The following is a description of a gene set: The directed movement of a protein to a specific location in a vacuole. studied in species Mus musculus Mouse Gene Set: GOBP_ESTABLISHMENT_OF_PROTEIN_LOCALIZATION_TO_VACUOLE, and this is the list of marker genes: Vps8, Snf8, Ap3b1, Vps28, Vps37c, Hspa8, Sort1, Atg14, Gcc2, Sqstm1, Vps53 (VPS53 GARP complex subunit), Vps54, Vps41, Ncoa4 (nuclear receptor coactivator 4), Igtp, M6pr, Clu, Gnptab, Ap3d1, Lhcgr, Mon1b, Vps13d, Sorl1, Lyset, Irgm2, Vps13c, Mon1a, Irgm1, Gga3, Vps37a, Lamp2, Snx16, Nedd4, Scarb2, Becn1, Tnfaip3, Vps37b, Ptpn23, Vps36, Smurf1, Vps25, Vps4a, Stam, Pik3r4 (phosphoinositide-3-kinase regulatory subunit 4), Vps13a, Pik3c3, Zfyve16, Ndp, Rab7, Ap4m1, Laptm5, Hgs, Vps37d